Given this list of marker genes THAP10, ZNF112, LYPD1, CDK5 (cyclin dependent kinase 5), BDH2, WTAP, AP2A2, POP5, FUT4, HOXA10, SYNPO, ELOA, PPARD, NXF1, B3GAT3, DNAAF2, WDR77, PSME3, PAN2, PYCR3, FBXL18, BRCC3, IVNS1ABP, EID1, ARF3, LSM2, FAM8A1, FAM200C, GBP1, TLE4, FKTN, THBS1, SLC5A6, ADAM10, RAB27A, THYN1, BIN3, PRIM1, CDKN3, PIGK, DNPH1, PLGRKT, NUDT6, FANCA, ZNRD2, WNT5A, GM2A, HNF1B (HNF1 homeobox B), FHOD1, CLN6, PTPN18, PGRMC1, NUBPL, ADO, AMD1, CDCA4, M6PR, PXMP4, MGST2, EXTL2, NDUFA3, CBR3, MRPS17, MAT2A, CYP24A1 (NCBI Gene Id 1591), DPY19L1, ORC1, ZNF365, HCFC1R1, NDUFB7, KIF18B, TMEM109, POGLUT1, RAD51C, ERLIN1, ANAPC13, ADAT1, SMARCD2, SDC2, DARS2, SNRNP25, GLIPR1, NDUFAF7, TUG1, PHTF1, ATR, BRIP1, NCOR2, TBC1D2, YLPM1, LCP1, NUAK2, RIDA, CXXC1, NEK2, REXO5, NDUFA7, TACSTD2, TBC1D2B, SLC16A7, PPM1F, UBR7, FOXL2, ANP32A, DLEU1, SCAND1, HHEX, PDLIM5, SLC39A8, PDF, ERG28, NHLRC2, TRIM34, CMC4, SERPINE1, PCDHGC3, POLR2L, TRAM2, EXOG, GTF3C2, LMNB1, CCND3, CRIM1, HOPX, BLCAP, PPOX, CCDC28B, MYCBP, ISOC1, ARSJ, CTPS1, MYL9, ANAPC15, ANTKMT, WDR5B (WD repeat domain 5B), PSME3IP1, USB1, B4GAT1, UTP3, RAC2, TAGLN, PSRC1, FJX1, GABBR2, RPS6KB2, NMB, TMEM160, TMEM80, RABIF, LIPA, EXO1, C7orf25, FABP4, POLR2I, MCCC2, ERMP1, MRPL34, ENSA, SMTN (NCBI Gene Id 6525), AP1S1, TCTA, STX8, CAV2, MLPH, CLDN11, MANSC1, MRPL24, E2F1, NME3, AMOTL2, ZBTB18, CHPF2, DGCR6, ACP6, RRAGA (NCBI Gene Id 115960), MLXIP, MCM3 (minichromosome maintenance complex component 3), WDR76, LANCL1, MCM10, GPR3, BARD1, SPC25, FGFBP1, PWP2, FEM1B, RRS1, ATP6V0E2, CDK1, NREP, CSTF2T, MRPL57, DPM2, HOXA1, TGFBR2, ADAM12, STX10, OSTF1, FNTB, WDCP, BOLA1, ANKFY1, SRF, DERA, NF2, ZNF239, DTYMK (deoxythymidylate kinase), PEX12, LMNB2, TSEN2, MCAT (NCBI Gene Id 91700), CLN5, ID3, PPP1R3C, SMCO4, BTD, ZMYM3, LRP8, COA1, PSMB9, COL4A2, ZBTB25, LINC01963, EN1, TLR4, TUSC2, FN1, FIRRM, SAC3D1, HDDC2, DET1, ASTE1, MBTPS2, PYCARD, SNU13, IQCC, DHODH, VCAN, MRPL40, TNS3, RSAD1, TCTN3, TRIM14, SLC25A11, TXN2, PDGFB, POLA2, METTL13, NEDD4L, BCL2A1 (BCL2 related protein A1), MPPE1, SLC43A3 (NCBI Gene Id 55543), PTCD2, CDC7, PNPLA4, ATRN, CISD1, NGF, CFLAR, NAV3, EBP, PEX11B, DHRS11, CD302 (NCBI Gene Id 9936), SMURF2, TMEM177, EIF2B1, FOCAD, RTL10, NLK, EHMT2, PRR16 (NCBI Gene Id 51334), MSRB2 (NCBI Gene Id 51648), SUB1, ALG6, ENDOG, C11orf71, PCSK6, USP13, CREBZF, TTPAL, TREX1, PAGR1 (PAXIP1 associated glutamate rich protein 1), TOP2A, HYAL2, EMC9, THAP11, GMPR2, PIGF, DOK1, TRMT12, AURKA, INTS9, C9orf40, BUB1, DNA2, BCL2L1, PCDH7, NME7, TEX261, ZHX3, NMU (NCBI Gene Id 10874), ADRB2, COA4, DHFR, ATXN10 (ataxin 10), MTARC2, NASP, NID1, INTS5, ID1, GPAA1, ICAM3, ISG15, APOL1, CCNE1, PON2, RBL2, TMEM14A, TARDBP, PIGN, ALDH1B1, HK2, DOLK, TIMM8B, CCNA2, NAAA, TRMT2B, SSX2IP, CCNF, SRSF8, JRK, NNMT, FBN1, ETFB, GGCX, HLA-DPA1, ZDHHC3, LEF1, IPP, ELOVL6, CNN2, HOXB7, ST3GAL4, HELLS, JAG1, CCN2, TMCO6, PITX1, CTNNBIP1, RMDN3, GALNT6, GSTT2, IFIT5, APBA2, LYSET, PRMT7, PTPRN2, NTHL1, MAPK14, CD40, NR2F1, ANTXR1, TTLL12, DPM3, SPARC, PIGC, TUBB, KANK1, NAA40, TRIAP1, IL13RA1, LOXL1, NUDT1, MEIS2, VCL, PCYOX1L, DDX11, RAD54B, APEX2, RHOBTB3, PGRMC2, IVD (isovaleryl-CoA dehydrogenase), RAB38, LCMT2, CARD10, NRGN, COL4A1, DBI, C1orf216, SH2D4A, CCDC15, RNASET2, COX16, BLOC1S1, FANCF, ACSL5 (acyl-CoA synthetase long chain family member 5), ISOC2, TTLL4 (tubulin tyrosine ligase like 4), TIMM8A, RFC3, CDCA3, USP18, CADM1, ITGB3, SURF2, H2AX, MDH2, WWC1 (WW and C2 domain containing 1), POLM, CTDSPL, NHP2, GEMIN6, GATC, HOXA9, KIFC1, ROR1 (receptor tyrosine kinase like orphan receptor 1), BDNF, CCND1, LAGE3, SLC25A12, ERLIN2, MECP2, BIRC5, SZRD1, PPIC, SHMT1, MLLT11, LOXL2, TIMM10, CDC42EP3, TASP1 (taspase 1), ELP5, ZNF22, KIF15, GEMIN4, CTSC, C16orf95, TGM2, CSTF1 (cleavage stimulation factor subunit 1), ARHGDIB, RRM2, UROS, XPA, EFEMP1, DENND2B, EXOSC4, PPP2R2D, ENDOD1, SETMAR, POGLUT2, UGGT2, SLC37A4, FBXO5, ZDHHC4, SLC26A2, SPIN2A, EEF2KMT, LBH (LBH regulator of WNT signaling pathway), AGPAT1, HMBS, FERMT1, TMX1, PIMREG, DBF4, TPM4, SEPHS1, FOXD1, ARL5A, FBXO9, CCN1, EHD3, PARP2, PLXNA2, UBTF, TSPAN1, PKP4, HADH, FARSA, DCTPP1, DHRS1, IGF2BP3, VOPP1, SKP2, CLTB, HMOX2, SDHAF3, MED22, PXMP2, KIF20A, FUCA1, MRPS34, HES1, MPC1, MDFIC, UBQLN2, DFFB (DNA fragmentation factor subunit beta), BDH1, RANBP6, PLCXD1, GPR176, AURKB, UQCR10, KANK2, TGIF2, UCP2, POLR3K, PMS1, MDM1, RGS7, ZBTB14, PLAU, PAQR4, EFEMP2, MKI67, BCL7C, C6orf120, MRPS14, CCDC85B, DUT, LIPT1 (lipoyltransferase 1), EML4, CBY1, CORO1A, VANGL1, RGS4, IRS1, CDKN2C, ABHD14A, ZFHX4, ATP2A2, ARAP2, PGP, AK1, DEAF1, TNFAIP1, HILPDA, MPHOSPH9, MPZL2, EEF1AKMT3, NDUFS6, JPT2, PARD6A, METTL18, EBAG9, COPS7B, SIX1, PDSS1, PGAP2, PUDP (pseudouridine 5'-phosphatase), PRSS23, TOR3A, WDR7, OSBPL3, TM7SF2, SYNJ2BP, SLFN12, MREG, SOX9, LAPTM5, AK2 (NCBI Gene Id 83165), CHST2, SLC38A6, ZNF174, MRPS11, SRGN, ICAM1, GINS4, IMP3, GCHFR, KIAA1549L, MTMR1, PNN, IGFBP5, N6AMT1, TGFB2, KCTD14, RBM8A, PLK2, MALL, ATP5MC1, UBXN8, POLR1G, AP3M2, ACOT13, TBL1X, CCL2, GLRX5, DEPTOR, BAG5, SPTSSA, POLE2, FZD1, ADAMTS3, BCS1L, CENPS, CENPI, EFHD2, SRSF7, TGFBI, SEPTIN7, SLC25A20, GALNT10, PTDSS1, RNFT2, DAG1, ZNF512B, F8A1, AGBL5, EDN1, INHBB, MAP3K5, PIGO, JADE1, CALD1, GINS2, GALNT14, ICMT, TMX4, MEAK7, TM7SF3, TSPAN4, B4GALT6, DCAF8, BOLA2, PIP4K2B, ALG8, EML3, PLCL2, INAVA, ALDH5A1, BCL2, PSMB10, CKLF, HJURP, CYB5A, BSCL2, ZNF93, EPHA2, ENC1, THTPA, FPGT, NLRP3, NEIL3, TMSB15B, HEXIM1, here is a description of the gene set: Genes down-regulated in T24 (bladder cancer) cells in response to the photodynamic therapy (PDT) stress. studied in species Homo sapiens from publication Buytaert E, Matroule JY, Durinck S, Close P, Kocanova S, Vandenheede JR, de Witte PA, Piette J, Agostinis P (PMID 17952126) Human Gene Set: BUYTAERT_PHOTODYNAMIC_THERAPY_STRESS_DN Photodynamic therapy (PDT) is an anticancer approach utilizing a light-absorbing molecule and visible light irradiation to generate, in the presence of O(2), cytotoxic reactive oxygen species, which cause tumor ablation. Given that the photosensitizer hypericin is under consideration for PDT treatment of bladder cancer we used oligonucleotide microarrays in the T24 bladder cancer cell line to identify differentially expressed genes with therapeutic potential. This study reveals that the expression of several genes involved in various metabolic processes, stress-induced cell death, autophagy, proliferation, inflammation and carcinogenesis is strongly affected by PDT and pinpoints the coordinated induction of a cluster of genes involved in the unfolded protein response pathway after endoplasmic reticulum stress and in antioxidant response. Analysis of PDT-treated cells after p38(MAPK) inhibition or silencing unraveled that the induction of an important subset of differentially expressed genes regulating growth and invasion, as well as adaptive mechanisms against oxidative stress, is governed by this stress-activated kinase. Moreover, p38(MAPK) inhibition blocked autonomous regrowth and migration of cancer cells escaping PDT-induced cell death. This analysis identifies new molecular effectors of the cancer cell response to PDT opening attractive avenues to improve the therapeutic efficacy of hypericin-based PDT of bladder cancer.